Given this list of marker genes Arhgap26, Actc1, Ophn1 (NCBI Gene Id 94190), Pkn2, Arhgdig, Bcr, Arhgap5, Arhgef10l, Jup, Tjp2, Stard8, Arhgef28, Rhob, Stk10, Arhgap1, Arhgap21, Mcf2l, Arhgef2, Snap23, Arhgap39, Ect2, Arhgef10, Arhgef25, Arhgap32, Mcf2, Flot1, Pkn3, Cav1, Daam1, Net1, Arhgap35, Cavin1, Vangl1, Arhgef11, Stom, Rock2, Rtkn, Depdc1b, Pcdh7, Myo9a, Abr, Diaph1, Racgap1, Pkn1, Stard13, Dlc1, Sowahc, Rhpn2, Pik3r2, Prex1, Diaph3, Vav2, Slk, Pik3r1, Tfrc, Vamp3, Arhgef1, Akap13, Iqgap3, Erbin, Flot2, Myo9b, Arhgef5, Mcam, Arhgef3, Arhgef17, Rock1, Anln, Arhgef12, here is a description of the gene set: studied in species Mus musculus Mouse Gene Set: REACTOME_RHOB_GTPASE_CYCLE RHOB GTPase cycle